Given this list of marker genes GAD1, CAD, SLC38A1, ABAT, ALDH18A1, SRR, GAD2, ALDH1A1, DPYD, OTC, PARK7, UPB1, CPS1, ATP2B4, PLOD3, PLOD2, SLC1A3, here is a description of the gene set: Human Gene Set: GOBP_NON_PROTEINOGENIC_AMINO_ACID_BIOSYNTHETIC_PROCESS The chemical reactions and pathways resulting in the formation of non-proteinogenic amino acids. studied in species Homo sapiens